Given this list of marker genes Serpine1, Creb1, Rac1 (NCBI Gene Id 52352), Cdc42, Bdnf, Shc1, Ngfr, Bcl2, Mapk4, Bax, Ntrk2, Frs2, Plg, Plat, Trp53, here is a description of the gene set: studied in species Mus musculus Mouse Gene Set: WP_BDNF_PATHWAY BDNF pathway